Given this list of marker genes MMP25, GNG2, ARF5, PADI2, ARHGEF9, CMTM7, THYN1, NAA38, TMEM14C, TRIM8, VSIG4, PRKCE, VEGFA, FXYD6, MPG, CLEC11A, TTC7A, BRPF1, IFI44L, CD37, FN3KRP, SIN3B, NDST1, RASSF2, RPRD2, NDUFS7, TMX4, IFITM1, SURF1, RBMS1, FBP1, BCL6, MRPL48 (mitochondrial ribosomal protein L48), DNMT3A, LRMDA, NREP, TBCD, ANXA6, NRTN, STX11, RAB3D, NRGN, ARPIN, BABAM1, PTPN22, CTSO, LAPTM5, POLM, ZNF652, TESK2, ASB13, MTX1, HVCN1, ERMN, FXYD5, ZFP36 (ZFP36 ring finger protein), FAM118A, COX6C, CCNQ, SSBP4, TCN2, LAMTOR1, GARS1-DT, ALDH1A1, ESYT1, ADD3, IDUA, ASGR1, CCDC6, BIN2, PLBD1, TMEM170B, TMEM219, SLC18B1, HDHD5, DGKG, SLF1, ANKDD1A, ALAD, NRIP1, ITGA4, ERICH1, HMGN2, CDKN2D, ATG16L2, CALM2, CPPED1, THUMPD2, GDI2 (GDP dissociation inhibitor 2), ASGR2, CYP2J2, FAM53B, MRPL40, PYGL, CAPNS1, TACC3, PIGS, FGL2 (NCBI Gene Id 10875), C11orf21, NAPRT, KBTBD11, NDRG3, GNAS, ZBED10P, DENND1C (DENN domain containing 1C), RAB27A, KLF7, CPNE3 (copine 3), NMD3, WDR91, P2RY13, MPZL3, PTP4A2, MTMR1, PSMG2, GPD1L, MPPE1, H2AJ, PHAF1, ZBTB18, ANAPC15, AVEN, KCMF1, LIN7A, TRDMT1, SAMD4A, HDDC3, PSMB9, CHPT1, TLR6, FCGR1A (NCBI Gene Id 50698), TXNDC11, CDC40, OR52K3P, VCL, GGTA1, GALT, MZT2A, CCDC85B, ZNF865, FBXL17, ARHGAP1 (Rho GTPase activating protein 1), PTP4A1, GAPDH, C3orf33, IFI44, TIGD3, SIDT1, SPMIP4, UBE2D2, NR4A1, CAMK1, SNTB1, DIS3L, ARMH1, SRRM5, MAP4K1, CLSTN1, IDH3G, KLF2, IL12RB1, ANP32A, MED30, BMF, HEBP2, DCTN3, TMC8, TLE3, UBTF, NDUFB1, OXA1L, ZG16B, NAPSB, NAT14, REX1BD, AMT, MPP7, PCIF1, EIF2S3, SAT2, HOXB5, NUDT3, TRAPPC1 (trafficking protein particle complex subunit 1), S1PR3, COMMD1, VAMP5, NDUFA10, ABHD14B, CELF2 (CUGBP Elav-like family member 2), RASGRP2, DCPS, IGFBP7, MLST8, FAM216A (family with sequence similarity 216 member A), TM7SF3, CRISPLD2, GPR65, COMT, here is a description of the gene set: Human Gene Set: GSE2770_TGFB_AND_IL4_ACT_VS_ACT_CD4_TCELL_48H_DN species: Homo sapiens Genes down-regulated in CD4 T cells activated by anti-CD3 and anti-CD28: TGFB1 and IL4 (48h) versus untreated (48h). from publication Lund R, Aittokallio T, Nevalainen O, Lahesmaa R (PMID 14607935) Th1 and Th2 cells arise from a common precursor cell in response to triggering through the TCR and cytokine receptors for IL-12 or IL-4. This leads to activation of complex signaling pathways, which are not known in detail. Disturbances in the balance between type 1 and type 2 responses can lead to certain immune-mediated diseases. Thus, it is important to understand how Th1 and Th2 cells are generated. To clarify the mechanisms as to how IL-12 and IL-4 induce Th1 and Th2 differentiation and how TGF-beta can inhibit this process, we have used oligonucleotide arrays to examine the early polarization of Th1 and Th2 cells in the presence and absence of TGF-beta after 0, 2, 6 and 48 hours of polarization.